The following is a description of a gene set: This event has been computationally inferred from an event that has been demonstrated in another species.<p>The inference is based on the homology mapping from PANTHER. Briefly, reactions for which all involved PhysicalEntities (in input, output and catalyst) have a mapped orthologue/paralogue (for complexes at least 75% of components must have a mapping) are inferred to the other species. Reactome Pathway: Heme biosynthesis species: Mus musculus part of: Metabolism of porphyrins electronically inferred by orthology from the curated human pathway, and this is the list of marker genes: Alas2 (aminolevulinic acid synthase 2, erythroid), Uros (uroporphyrinogen III synthase), Alb, Alad, Cox10, Abcg2, Urod, Ppox, Fech